Given this list of marker genes Hspa1b, Stk17b, Sh3kbp1, Rgs10, Macf1, Cd52, Pfdn5, Ccl5, Mxd4, Zbtb20, Slamf6, Nrp1, Rsrp1, Nck1 (non-catalytic region of tyrosine kinase adaptor protein 1), Smpdl3a, Rgs2, Hmgb2, Hspa1a, Rgs3, here is a description of the gene set: from publication Cui A, Huang T, Li S, Ma A, Pérez JL, Sander C, Keskin DB, Wu CJ, Fraenkel E, Hacohen N (PMID 38057668) Cytokines mediate cell-cell communication in the immune system and represent important therapeutic targets. A myriad of studies have highlighted their central role in immune function, yet we lack a global view of the cellular responses of each immune cell type to each cytokine. To address this gap, the authors created the Immune Dictionary, a compendium of single-cell transcriptomic profiles of more than 17 immune cell types in response to each of 86 cytokines (>1,400 cytokine-cell type combinations) in mouse lymph nodes in vivo. A cytokine-centric view of the dictionary revealed that most cytokines induce highly cell-type-specific responses. For example, the inflammatory cytokine interleukin-1β induces distinct gene programmes in almost every cell type. A cell-type-centric view of the dictionary identified more than 66 cytokine-driven cellular polarization states across immune cell types, including previously uncharacterized states such as an interleukin-18-induced polyfunctional natural killer cell state. Genes negatively differentially expressed in cell type: Treg upon treatment with cytokine: IL-7 in mouse lymph nodes in vivo. Mouse Gene Set: CUI_TREG_IL7_RESPONSE_DN studied in species Mus musculus